Given this list of marker genes LRP8, APOL5, HSPD1, TREM2, PLTP, ABCA1, MIR30C1, CD36, APOA2, MIR9-1, SCARB1, APOL2, APOA1, here is a description of the gene set: Human Gene Set: GOMF_HIGH_DENSITY_LIPOPROTEIN_PARTICLE_BINDING species: Homo sapiens Binding to high-density lipoprotein particle, a lipoprotein particle with a high density (typically 1.063-1.21 g/ml) and a diameter of 5-10 nm that contains APOAs and may contain APOCs and APOE.